The following is a description of a gene set: Any process that stops, prevents, or reduces the rate of cold-induced thermogenesis. species: Homo sapiens Human Gene Set: GOBP_NEGATIVE_REGULATION_OF_COLD_INDUCED_THERMOGENESIS, and this is the list of marker genes: NPR3, STK11, TLR4, ABHD6, TFE3, CIDEA, LAMA4, FLCN, IP6K1, ZNF423, ACOT13, FOXC2, ARRDC3, PCTP, IL15, LGR4, WNT10B, RHEB (NCBI Gene Id 6009), QKI, ALDH1A1, NR1H2, ADIPOQ, NR1D1, ACVR2B, ADAM17, PLCL2, ID1, NR1H3, NOVA2, RB1, BMAL1, PGAM5 (PGAM family member 5, mitochondrial serine/threonine protein phosphatase), DOCK7, LNPEP, NOTCH1, NRDC, IL18R1, DDIT3, ACOT11, PLCL1, TLE3, RBPJ, ADAMTS5, ATF4, MAP2K6, HOXC10, NOVA1, ACTN3